The following is a description of a gene set: Any process that stops, prevents, or reduces the frequency, rate or extent of the assembly of actin filament bundles. Human Gene Set: GOBP_NEGATIVE_REGULATION_OF_ACTIN_FILAMENT_BUNDLE_ASSEMBLY species: Homo sapiens, and this is the list of marker genes: ARHGAP6, PPFIA1, PRKN, TACSTD2, WASF2, CLASP1, MET, MIR149, PHLDB2, RHPN1, TJP1, ARHGAP28, CORO2B, TMEFF2, MIR21, ARAP1, SHANK1, MIR20A, PFN1, SHANK3, CFL1, ARHGEF18, RHPN2, PAK2, S1PR1, FRMD7, MIR138-1, CGNL1, F11R, MYOC, INPP5K, CLASP2, STMN1, RHPN2P1, PIK3R1, OAZ3 (NCBI Gene Id 51686), WAS, DLC1